The following is a description of a gene set: studied in species Homo sapiens Genes having at least one occurence of the motif ACTGCCT in their 3' untranslated region. The motif represents putative target (that is, seed match) of human mature miRNA hsa-miR-34b (v7.1 miRBase). Human Gene Set: ACTGCCT_MIR34B, and this is the list of marker genes: WASF1, CELF3 (NCBI Gene Id 11189), MAN2A2, PIEZO2, ETS1, HTR2C, ACACA, MIER2, ELMOD1, SPTBN2, FOXP1, PPP1CC, SHISA7, MAT2A, BEST1, ATP11C, SPEG, MTDH, ARHGAP1 (Rho GTPase activating protein 1), BOLA2, NAV1, ICA1, VAMP2, STRBP, ARHGEF10L, ARRDC3, IQGAP2, RALGPS2, MED13, ACTL6A, MARCHF5, FOXJ2, NAA50, CELSR3, MAPK1, TMEM87A, VAMP3 (vesicle associated membrane protein 3), STIM1, RAP1GAP2, INSM1, SETD7 (NCBI Gene Id 80854), RIMBP2, GLCE, CYRIB (CYFIP related Rac1 interactor B), XKR6, ZNF207, ELAVL1, ANK2, ESRRA, NR4A2, PRR3, HOXC8, BCL9L, ATP1B3 (ATPase Na+/K+ transporting subunit beta 3), NDST1, JAG1, PLEKHA1, MYB, TESK1, POU4F1, TCF12, BTG2, STC1, OCRL, TFDP2, CACNA2D2, ITSN1, ZNF3, ZZZ3, SHISA6, PAPOLA, ARID1B, JAZF1, MAGI1, JADE2, GRM1, MYCBP2, ZNF148, GEMIN8, NFAT5, ALCAM, YTHDF1, VEZT, ARID4B, ANKRD12, ELF2, LMAN2L, ABCC1, MTCL2, DCAF7, DHX40, TRIM2 (NCBI Gene Id 23321), SOX4, RAB14, MLLT3, PTK7, MAPK4, ARL5B, DIP2C, ANGPTL7, TOX, PPP6R2, ERLIN1, RPS6KB1, KCTD16, ACTR1A, RAB10, PPP2R5A, DAAM1, AP2S1, NUFIP2, ZMPSTE24, CNOT4, AHCYL2, RBM12 (RNA binding motif protein 12), PPP1R10, CALCR, SENP3, PDGFRA, PIAS1, ERGIC1, TSPAN32, PLEKHG5, EDARADD, FAM219A, HOXB8, SFSWAP, MSI1, HYCC2, RNF4, CREB1, ARNT2, FOXN3, RDX, NRG1, ACSL1, AP3M1, MYRIP, AP1B1, EVI5L, TMCC3, SNTA1, COL12A1, UHRF2 (NCBI Gene Id 49857), RBM24, YWHAZ, NFIX, RIC8B, MTCL1, MYC, MAP1A, RAB3C, VEGFA, NPTX1, MIDEAS, PTPRG, NETO1, MET, ST18, STK39, DMAC2L, PURB, RPS6KA4, FLOT2, PHACTR1, SYNGR1, ATXN2L, DLL1, ARID2, AMER1, NAV3, KLF12, CAPN6, FAM171A1, TENM1, PAPOLG, SDHC, FHL2, B4GALT2, MOB1B, TAOK1, SUCO, ADGRL1, JAKMIP1, IRF6, LRP6, GRID1, AKAP1, MRPL52, BRD4, HPS1, MORN4, NOTCH1, MOSPD1, MARCHF6, CDK6, FRMD4A, PAK1, NEUROD1, ARPP21, HMBOX1, ADCY2, MECP2, CNTNAP1, ZNF282, RALA, RANBP10, CNOT6, CERS2, ADORA2A, THRB, CTNND2, NSUN5P2, CPEB3, ZMYM3, MITF, ZNF580, CELF2, PCF11, ANKS1B